Given this list of marker genes TACC1, ZNFX1, TMOD3, CYB5B, DHX40, IL6ST, SAR1B, BCAP31, G3BP2, TWSG1, DNAJC3, LPGAT1, SLC38A2, SYPL1, PLXND1, SRP9, UXS1, DHX9, SLC30A1, GALNT1, ADIPOR1, NUP133, PRRC1, HDHD2, NCSTN, LRP11, AP3B1, TOR1AIP1, ANKRA2, ADSS2, BIVM, MAEA, TENM4, GLO1, OCLN, SOS1, ELOVL5, ITGB1, TAF9B, PCYOX1, IGF2R, AP2B1, ARPC5, LRRC8A, ACBD3, ZNF655, N4BP2, PRUNE1, BAIAP2L1 (NCBI Gene Id 55971), B3GNT2, ASXL2, MANF, GSKIP, PTTG1IP, ATP11A, RAB6A, C1orf43, TBCE, CNIH1, NSF, GOLT1B, PAICS, RTN3, BCKDHA, STAG2 (NCBI Gene Id 10735), ZNF271P, GIGYF1, DSP, VPS72, SP3, SF3B1, CDK13, PIK3R1, ARFGEF2, CDV3, DYNC1H1, RHOBTB3, CHPF, ORC3, MBNL1, MAP3K8, LNPEP, VPS50, IDI1, IDE, DEGS1, HMGCR, BMI1, TOMM20 (NCBI Gene Id 9804), SSR1, ATP5MK, UNG, TRIM24, NONO, TMED10, ZNF490, SUCO (SUN domain containing ossification factor), TWF1, WIZ, CCDC88A, PDIA4, CAB39, DLG1, TADA1, PPP1CC, TBC1D1, SLC25A32, APLP2, TMED2, DDX5, HMGCS1, PACC1, DYNLT3, TNPO1, ROBO1, PPP2R5A, SLMAP, PIK3R4, IL2, FADS2, here is a description of the gene set: studied in species Homo sapiens Genes in the cancer module 239. Human Gene Set: MODULE_239